Given this list of marker genes DCUN1D3, TMEM47, OPHN1, CLCF1, VEZF1, ATXN3, CCN1, ITSN1, CEMIP2, YTHDF2, YAF2, ARK2N, ARID1A, UBAP2, APLN, ZNF436-AS1, ZBTB1, MARCKS, MTHFD1L, SLC7A11, GK5 (NCBI Gene Id 256356), GREB1L (GREB1 like retinoic acid receptor coactivator), AP3S1, CMTM6, HERC4, PUM1, AFF4, DGCR2, ETS1, RWDD4, MLLT6, UBE2K, G3BP2, KCND2, EFNA3, RSBN1, MEF2D, SOX30, ETNK2, NOTCH2, FSTL1, OSBPL3, GABBR1 (gamma-aminobutyric acid type B receptor subunit 1), SUMO2, MTF2, RAP1B, DCX (NCBI Gene Id 1641), FRAS1, NALF2, AUTS2, CPEB2, ULK2 (NCBI Gene Id 9706), LZTS3, SGPL1 (sphingosine-1-phosphate lyase 1), C2CD6, SLC9A2, ETV1, QSER1, IQGAP1, ATRN, KPNA1, PSMD11 (NCBI Gene Id 5717), NCS1, TMEM263, CEP192, PM20D2, NFIB (NCBI Gene Id 4781), TACC1, SLC4A4, RBL2, ALKBH8, DONSON, RPP14, HERC2P9, PDGFRA, KLF14, NCOA1, CLSTN2, UBE2B, ABCC3, SERTAD1, SP4, UBE2Q2, ZFP36L1, RAP2C, DLG2, DDX3X, POM121, ARHGEF3, SOX12, ABCG4, RIOK3, SCN8A, MOSPD2, LRATD2, ZBTB44, GDI1, SNAP25, ARRDC3, CSNK1G1, CLIP2, SYNGR1, POU2F1, ISL1, ID3, FRMPD4, NUP35, BICRAL, UBE2H, NDUFAF5, BSN, ZFP91, HOXA1, HNRNPUL1, NSD2, CHSY1, KCTD7, BTG2, MARCHF6, DDX3Y, MCUR1, PIP4P2, MAPRE1, KRT18P55, SRSF1, EPC2, PLAGL2, EPN2, NFATC4, AHCYL2, AAR2, UHRF2, RDH11, RAB2A, MSI1, TNPO1 (NCBI Gene Id 3842), ZFAND4, CAB39, TGFBR2, KHNYN, EMX2, FGFR2, ZNF207, DIS3L2, RPS6KA3, CILK1, KMT2A (lysine methyltransferase 2A), MAEL, CLUHP3, here is a description of the gene set: Genes having at least one occurence of the motif TTGGAGA in their 3' untranslated region. The motif represents putative target (that is, seed match) of human mature miRNAs hsa-miR-515-5p and hsa-miR-519e* (v7.1 miRBase). Human Gene Set: TTGGAGA_MIR5155P_MIR519E studied in species Homo sapiens